Given this list of marker genes MARK4, STK11IP, BRSK2, CREB1, EZR, TSC2, MTOR, MAPT, SIK3, SIK2, YWHAE, MAP2, SMARCD3, YWHAB, MYC, YWHAG, YWHAH, MLST8, TSC1, HSP90AA1, MARK2, SFN, CAB39, AKT1S1, ESR1, GSK3B, TP53, PSEN2, CRTC2, BRSK1, SMAD4, STK11 (serine/threonine kinase 11), PRKAG1, PRKAB1, STRADA, STK26, YWHAQ (NCBI Gene Id 10971), CTSD, ETV4, PRKACA, CDC37, PRKAA2, STRADB, YWHAZ, RPTOR, PRKAA1, SIK1, here is a description of the gene set: LKB1 signaling events from publication Schaefer CF, Anthony K, Krupa S, Buchoff J, Day M, Hannay T, Buetow KH (PMID 18832364) studied in species Homo sapiens Human Gene Set: PID_LKB1_PATHWAY